The following is a description of a gene set: studied in species Mus musculus Mouse Gene Set: GOBP_EMBRYONIC_BRAIN_DEVELOPMENT The process occurring during the embryonic phase whose specific outcome is the progression of the brain over time, from its formation to the mature structure., and this is the list of marker genes: Mir34b, Ttbk2, Ppil1, Cntnap2, En2, Prickle1, Mfsd2a, Rpl10, Mir449c, Cc2d2a, Tra2b (transformer 2 beta), Mir449b, Mks1, Mir34c, Tbc1d23, Cdc40, Prickle2, Med12, Megf8, Rnf112, Cdk20, Ctnnb1, Mir449a, En1, Pcnt, Rpl10-ps3, Tmem94, Wnt1, Ift140, Tubb2b